Given this list of marker genes Kif26b (NCBI Gene Id 286945), Lhx1, Wt1, Smo, Six2, Sox8, Pax8, Agtr2, Pax2, Wnt4, Fmn1, Sall1, Foxj1, Hes5, Calb1, Cited1 (Cbp/p300-interacting transactivator with Glu/Asp-rich carboxy-terminal domain 1), Fgf10, Gdnf, Stat1, Hes1, Lif (NCBI Gene Id 16878), Sox9, Wnt9b, Pkd2, Grem1, Pkd1, Lgr4, Wnt7b, Fras1, Ctnnb1, Bmp4, here is a description of the gene set: The process in which the anatomical structures of the metanephros are generated and organized. Mouse Gene Set: GOBP_METANEPHROS_MORPHOGENESIS species: Mus musculus